Given this list of marker genes Decr2 (2-4-dienoyl-Coenzyme A reductase 2, peroxisomal), Pex5, Crat, Serp1, Crot, Mlycd, Hsd17b4, Sgta, Uba52rt, Nudt19, Hmgcl, Zfand6, Acot3, Pex19 (peroxisomal biogenesis factor 19), Baat, Pex11b, Gnpat, Ube2j2, Pecr, Pex7, Dhrs4, Nos2, Otc, Pex10, Stx1a, Ube2d1 (ubiquitin-conjugating enzyme E2D 1), Ubb, Ndufb8, Hao1 (NCBI Gene Id 15112), Pex3, Rps27a, Coq2, Uba52, Emd, Vapa, Lonp2, Ephx2, Mpv17, Nudt7, Atad1, Abcd3, Ech1, Abcd2, Stx5a, Usp9x, Acot1, Pex12, Pex14, Gdap1, Ide, Ube2d3, Pex2, Vamp2, Acot2 (acyl-CoA thioesterase 2), Cyb5a, Pex16, Ehhadh, Acox2, Fis1, Prnp, Pxmp4, Pex6, Agxt, Slc25a17, Pex1, Sec61b, Amacr, Sec61g, Atp5mc3, Acot4, Tysnd1, Paox, Phyh, Abcd1, Ddo, Fxn, Hscb, Acbd5, Pex13, Pipox, Sec61bl, Acot5, Acox3, Aldh3a2, Hmox1, Eci2, Hacl1, Pitrm1, Gstk1, Dao (D-amino acid oxidase), Hao2, App, Acot8, Idh1, Acox1, Cat, Hspd1, Ube2d2a, Slc27a2, Scp2, Ubc, Atp5f1b, Ldhd, Acaa1b, Pex26, here is a description of the gene set: studied in species Mus musculus Mouse Gene Set: REACTOME_PROTEIN_LOCALIZATION Protein localization